The following is a description of a gene set: studied in species Mus musculus Mouse Gene Set: GOMF_ANKYRIN_BINDING Binding to ankyrin, a 200 kDa cytoskeletal protein that attaches other cytoskeletal proteins to integral membrane proteins., and this is the list of marker genes: Ptprc, Slc4a1, Atp1a1, Cdh1, Obscn (NCBI Gene Id 380698), Iqschfp, Scn5a, Sptbn1, Kctd6, Rhag, Plec, Cacna1d, Flnc, Nrcam, Rhcg (NCBI Gene Id 56315), Rhbg, Sptb, Cltc, Slc8a1, Sptbn4, Kcnj11, Kcnq2, Ttn